Given this list of marker genes Tmem100, Dll1, Notch1, Hey2, Hey1, Rbpj, here is a description of the gene set: Mouse Gene Set: GOBP_ARTERIAL_ENDOTHELIAL_CELL_DIFFERENTIATION The process in which a relatively unspecialized endothelial cell acquires specialized features of an arterial endothelial cell, a thin flattened cell that lines the inside surfaces of arteries. studied in species Mus musculus